Given this list of marker genes Arrb2, Tgfb1, Gipc1, here is a description of the gene set: studied in species Mus musculus part of: Signaling by TGFBR3 This event has been computationally inferred from an event that has been demonstrated in another species.<p>The inference is based on the homology mapping from PANTHER. Briefly, reactions for which all involved PhysicalEntities (in input, output and catalyst) have a mapped orthologue/paralogue (for complexes at least 75% of components must have a mapping) are inferred to the other species. electronically inferred by orthology from the curated human pathway Reactome Pathway: TGFBR3 regulates TGF-beta signaling